Given this list of marker genes Aldoart2, Gm7763, Arhgap5, Pnn, Gm2395 (predicted gene 2395), BC042761 (cDNA sequence BC042761), Gm25970, Gm24750, Rpl7a-ps1, Gm46329, Gm48268, 1700030L22Rik, Gm15524, Gm5786, Gm2446, Dtd2, Psma6, Ralgapa1, Mipol1, Gm16246, Npas3, Gm2436, Gm29809, Gm6068, Sfta3-ps, Gemin2, Gm4930, Eapp, Togaram1, Gm22973, Akap6, Gm36634, Gm20049, 1700104L18Rik, 4921518K17Rik, Gm46350, Nfkbia, Gm2412, Srp54a, Gm7557, Rpl18a-ps1, Gm25599, Gm6218, Gm22673, Ppp2r3c, Nkx2-9, Gm26973, Rpl26-ps2, Mis18bp1, Egln3, Sptssa, Gm31063, Gm7719, Mbip, Gm5653, Nubpl, Gm19134, Pax9, Gm32220, Sec23a, Gm18242, Cfl2, Rpl31-ps17, Klhl28, Srp54b, Slc25a21, Gm35818, Rpl21-ps3, Snx6, Prps1l3, Fscb, Nkx2-1, Gm2568, Gm7753 (NCBI Gene Id 677036), Gm5185 (NCBI Gene Id 382606), Gm22220, Mir1892, Sstr1, Wdr20rt, Gm5184, Srp54c, Gm25917, Gm7745, Prpf39, Gm30738, Gm4806, Gm40884, Gm47647, Gm36262, Fam177a, Gm32936, 1700081N11Rik, 1700031P21Rik, Gm26444, Gm26015, Foxa1, 2700097O09Rik, Gpr33, Gm46328, Gm24233, Spanxn4, Clec14a, Baz1a, Cox6c2 (cytochrome c oxidase subunit 6C2), Tspyl-ps, Gm35135, Gm5183, Gm24066, Gm24296, Lrfn5, Gm18339, Gm18871, Gm7511, Insm2, Gm20063, Gm23910, Trappc6b, Ttc6, Gm2754, Brms1l, Mia2, Heatr5a, Gm25760, Gm24377, 1700060O08Rik, Prorp, Gm48305, Gm17529, Gm18873, Gm19990, Fam177a2, Gm7550, Gm11025, Gm7739, Gm35188, Gm35239, Gm2649, Gm6353, Fbxo33, Dnajb6-ps, Gm22513 (predicted gene, 22513), Nanog-ps2, Gm7754, Gm7727, Fkbp3, Gm527, 4930471E15Rik, Fancm, Gm18027 (predicted gene, 18027), here is a description of the gene set: species: Mus musculus Mouse Gene Set: chr12C1